The following is a description of a gene set: species: Mus musculus The process in which the anatomical structures of cartilage are generated and organized. Mouse Gene Set: GOBP_CARTILAGE_MORPHOGENESIS, and this is the list of marker genes: Hand1, Matn1, Msx1, Hand2, Mef2c, Hoxa5, Lrp6, Rspo2, Snai1, Stc1, Wnt7b, Snai2